Given this list of marker genes KIT, TSC1 (NCBI Gene Id 7248), TRPM4, COL2A1, BTNL2, GLMN, RASA1, IFNG, EBP, TSC2, TNFRSF1B, GJB2, KRT5 (keratin 5), ADA2, CD28, CTLA4 (cytotoxic T-lymphocyte associated protein 4), KRT83, LAMB3, LORICRIN, TMC8, GJB6, KRT14, KRT10, SDHD, LAMA3, IL7, ECM1, MEFV, CFTR, PSMB8, AP1S3, ATP2A2, CIB1, TMC6, IDH1, IL36RN, LAMC2, HLA-DRB1, CARD14, MPDU1, COL7A1, PTPN6, GJB4, UBA1, KDSR, HAVCR2, LDHA, here is a description of the gene set: species: Homo sapiens A plaque is a solid, raised, plateau-like (flat-topped) lesion greater than 1 cm in diameter. Skin plaque Human Gene Set: HP_SKIN_PLAQUE